Given this list of marker genes SMAD7, TRAF2, PRKAB2, EIF2S1, PIK3R1 (NCBI Gene Id 5295), NDUFB5, NDUFC2-KCTD14, AKT3, COX7C, NDUFA1, NDUFA9, NDUFB6, NDUFS2, RAC1, CASP8, CCL2, SREBF1, LEPR, NDUFB7, UQCRC1, UQCRB, NDUFS4, MAPK9, MT-CO3, COX5B, PRKAG2, NDUFV1, NDUFA11, IL6, XBP1, UQCRC2, PPARA, CASP3, PIK3CD, COX4I1, JUN, MIR21, BID, NDUFA4, MT-CO2, NDUFS1, BBC3, PIK3R3, COX6A1, INS, UQCRFS1, CYCS, ADIPOR2, BAK1, COX7B2, SDHB, NDUFAB1, NFKB1, BAX, MAPK8, GSK3A, MLX, IL1B, COX7B, NR1H4, ITCH, COX8A, NDUFB9, IRS2, NDUFB1, NDUFA8, NDUFA7, CYP2E1, UQCRHL, NR1H3, NDUFC1, FAS, COX6C, BCL2L11, CXCL8, MT-CYB, COX7A2, IRS1, ADIPOR1, NDUFS7, PIK3CA, MAP3K11, NDUFB3, CEBPA, COX6B1, NDUFS5, NDUFB8, CASP7, MT-CO1, COX5A, SDHD, RXRA, NDUFA2, COX7A2L, MAP3K5, PRKAB1, RELA, COX6B2, NDUFA3, IL1A, DDIT3, IL6R, NDUFS8, IKBKB, FASLG, NDUFA12, PIK3R2, SDHA, TGFB1, NDUFB10, NDUFB11, NDUFC2, NDUFB2, TNF, NDUFS3, NDUFB4, PRKAA2, INSR, MLXIP, NDUFA6 (NCBI Gene Id 4700), PRKAA1, NDUFA10, NDUFA4L2 (NDUFA4 mitochondrial complex associated like 2), UQCRH, UQCR10, EIF2AK3, NDUFS6, PRKAG1, NDUFA13, NDUFV2, UQCRQ, AKT2, COX4I2, ATF4, LEP, NDUFV3, SDHC, CYC1 (NCBI Gene Id 1537), TNFRSF1A, AKT1, COX8C, PRKAG3, SOCS3, UQCR11, NDUFA5, PKLR, CDC42, COX6A2, ERN1, VCAM1, COX7A1, PIK3CB, GSK3B, MLXIPL, ADIPOQ, here is a description of the gene set: Human Gene Set: WP_NONALCOHOLIC_FATTY_LIVER_DISEASE Nonalcoholic fatty liver disease species: Homo sapiens